Given this list of marker genes Ddx21, Cdc14a, Basp1, Spred1 (sprouty protein with EVH-1 domain 1, related sequence), Cish, Chd7, Kmo, Gnb4, Tes, Psme2, Prkcd, Cyba (cytochrome b-245, alpha polypeptide), Pfkp, Fnbp1l, Ifi205, Arpc4, Serpina3g, Ncbp3, Cd40, Srsf2, Tuba1b, Pim1, Ccl17, Slfn2, Bcl2a1d, Txn1, Socs1 (suppressor of cytokine signaling 1), Rab14, Cox5a, Syngr2, Adam23, Bcl2a1b (NCBI Gene Id 12045), Mdh2, Tap2, Ppa1, Irf5, Pfn1, Bcl2a1a, Spi1, Cxcl9, Cst3, Nedd4, Denr, Cdkn1a, Rpn1, here is a description of the gene set: Genes positively differentially expressed in cell type: cDC1 (conventional dendritic cell type 1) upon treatment with cytokine: TL1A in mouse lymph nodes in vivo. Mouse Gene Set: CUI_CDC1_TL1A_RESPONSE_UP from publication Cui A, Huang T, Li S, Ma A, Pérez JL, Sander C, Keskin DB, Wu CJ, Fraenkel E, Hacohen N (PMID 38057668) species: Mus musculus Cytokines mediate cell-cell communication in the immune system and represent important therapeutic targets. A myriad of studies have highlighted their central role in immune function, yet we lack a global view of the cellular responses of each immune cell type to each cytokine. To address this gap, the authors created the Immune Dictionary, a compendium of single-cell transcriptomic profiles of more than 17 immune cell types in response to each of 86 cytokines (>1,400 cytokine-cell type combinations) in mouse lymph nodes in vivo. A cytokine-centric view of the dictionary revealed that most cytokines induce highly cell-type-specific responses. For example, the inflammatory cytokine interleukin-1β induces distinct gene programmes in almost every cell type. A cell-type-centric view of the dictionary identified more than 66 cytokine-driven cellular polarization states across immune cell types, including previously uncharacterized states such as an interleukin-18-induced polyfunctional natural killer cell state.